Given this list of marker genes SMC1A, RECQL, IFI30, EBNA1BP2, FH, OAT, CYCS, CYTIP, CCT6A, DBI, WARS1, RFC3, PSMA3, MRPL23, TFRC, LILRB4, PSMA5, VBP1, ANP32A, SNRPB2, CDK1, DLGAP5, CAPRIN1, TRA2B, PSMC5, PNP, TUBA1A, SLC25A46, ITGB7, IQGAP2, NFIL3, SSR1, HPRT1, PAK2, GIT2 (GIT ArfGAP 2), BAK1, BAG1, CASP1, TAX1BP3, NKRF, CDC123 (NCBI Gene Id 8872), TMPO, HPGD, DNAJC7, TOP2A, TOP2B, GGH, TKT, NDUFA9, TMEM97, PPP1R2, AFF1, TARS1, EIF3A, ANG, GZMB, MRPL58, SLA, PTPN1, GLDC, EWSR1, IGF1, KIF14, LDHB, U2AF2, CDC6, MTHFD2 (NCBI Gene Id 10797), RFC4, HSPA9, CD58, SLC39A7, CHAF1A, ELOC, KIF11, PSMB2, CDC20, PDAP1, RB1, EIF2S1, GART, COX7B, ETF1, SUMO2, MAD2L1, CCT5, NAE1, UQCRH, GALNT3, TOPBP1, CD70, PSMA2, RAB27A, GARS1, MPHOSPH6, COASY, GALNT1, MSN, BCL3, DTYMK, SLC19A1, CKS1B, ABCD3, FDPS, CLEC2B, PLK4, CASP6, YBX1 (NCBI Gene Id 7806), SRSF3, PHB1, BYSL, LSP1, ADD1, CLIC1, ZNF410, PAICS, PPIF, AHCY (NCBI Gene Id 191), FAS, FASN, CPOX, TROAP, HMMR, MAPKAPK3 (MAPK activated protein kinase 3), FOXM1, DDX39A, CBX5, CDC25B, S100A10, HUWE1, MAPK6, PSMD14 (NCBI Gene Id 10213), ATIC, ATP13A3, PFKP, XRCC6, USP14, TUBA4A, TIMM17A, DHFR, COX6C (cytochrome c oxidase subunit 6C), SCAP, PCNA, PGK1, CCT7, YARS1, ABCE1, AIMP2 (NCBI Gene Id 7965), SNRPG (NCBI Gene Id 6637), SLC16A1, PPP4C, RIPOR2, MKI67 (NCBI Gene Id 4288), PSMB8 (proteasome 20S subunit beta 8), KIF23, MYO5A, CDKN1A, PDLIM1, MAPK1, MRPL3, ATP1B3, STIL, HSPA4, CCT4, MYCBP, BLMH, FDFT1, TCP1, BOP1 (NCBI Gene Id 727967), ATP5PF, PRPS2, HSD17B10, ZMAT2, TOP1, ENTPD1, LIMS1, PWP1 (PWP1 homolog, endonuclein), RRM1, TTK, FABP5, GLIPR1, MCM3, CORO1A, TDG, CLCN3, EED, YWHAH, KIF2A, MRPL12, ORC1, KIFC1, PRKDC, CENPA, LGALS1, GSPT1, UCHL3, CCNE1, SELL, NDUFS1, GINS1, DHCR24, CCNB1 (NCBI Gene Id 891), GCLM, GNB1, TRAP1, RRM2, EBP, CCNF, PSMA1, MRPL19, ASNS, TYMS, PAPOLA, UCK2 (uridine-cytidine kinase 2), NARS1, LDLR, IL2RB, PRKCB, RPA1, ARHGDIB, ACOT7, LBR, UBE2L3, NME1, UBE2D3, NDUFV2, SNRPF, HMGB2, CRYBG1, SNRPC, SGK1, TRIP13, ACVR1, ACTA2, MTHFD1, RNASE6, POLD2, ATP5PB, HSPE1, TBCB (NCBI Gene Id 126386), UBE2S, OSTF1, ARID3A, KPNA2, ANXA6, ATP5PO, SDHB, CCT2, CCND2, PRIM1, FLNA, SMARCA4, CCNA2, NNT, ITGB1, CBX3, KDM5A, FOXK2, KIF2C, LMNB1, CRADD, UBE2C, TMSB10, PSMC3IP, EZH2, CKS2, ESPL1, KYNU, UQCRC2, CENPE, ELMO1, RARS1, COPS5, EIF5, EXOSC2, SNRPD3, PSME2, UFD1, PSME4 (NCBI Gene Id 23198), GET3, IQGAP1, PCLAF, CDKN3, VDAC1, KLHDC3, TUBG1, SUMO1, BRD8, KIF22, RRP1B, IDH2, IPO5, GPI, NASP, SOD2, MVP, DUT, PSMD4, CSE1L, GNL2, NEK2, CTPS1, CD180, SLC7A5, TXN, HNRNPC, CDC27, CD52, here is a description of the gene set: Human Gene Set: TARTE_PLASMA_CELL_VS_PLASMABLAST_DN species: Homo sapiens from publication Tarte K, Zhan F, De Vos J, Klein B, Shaughnessy J Jr (PMID 12663452) Genes down-regulated in mature plasma cells compared with plasmablastic B lymphocytes. Plasma cells (PCs), the end point of B-cell differentiation, are a heterogeneous cell compartment comprising several cell subsets from short-lived highly proliferative plasmablasts to long-lived nondividing fully mature PCs. Whereas the major transcription factors driving the differentiation of B cells to PCs were recently identified, the subtle genetic changes that underlie the transition from plasmablasts to mature PCs are poorly understood. We recently described an in vitro model making it possible to obtain a large number of cells with the morphologic, phenotypic, and functional characteristics of normal polyclonal plasmablastic cells (PPCs). Using Affymetrix microarrays we compared the gene expression profiles of these PPCs with those of mature PCs isolated from tonsils (TPCs) and bone marrow (BMPCs), and with those of B cells purified from peripheral blood (PBB cells) and tonsils (TBCs). Unsupervised principal component analysis clearly distinguished the 5 cell populations on the basis of their differentiation and proliferation status. Detailed statistical analysis allowed the identification of 85 PC genes and 40 B-cell genes, overexpressed, respectively, in the 3 PC subsets or in the 2 B-cell subsets. In addition, several signaling molecules and antiapoptotic proteins were found to be induced in BMPCs compared with PPCs and could be involved in the accumulation and prolonged survival of BMPCs in close contact with specialized stromal microenvironment. These data should help to better understand the molecular events that regulate commitment to a PC fate, mediate PC maintenance in survival niches, and could facilitate PC immortalization in plasma cell dyscrasias.